Given this list of marker genes Apoa2, Serpinb9, Klre1, Socs5, Rc3h1, Hfe, Inpp5d, Il20rb, Cd84, Jak3, Nectin2, Cd55b, Apoa1, C4bp, Mill1, Sh2d1b2, Arg1, Serping1, Lgals1, Klrb1b, Ceacam1, Zpbp2, Vsig4, BC037156, Cr1l, Grn, Ascl2, Lgals9, Il13ra2, Nod2, Clec4g, Serpinb9c, Zfp35, Hlx, H2-T23, Ccr2, Epx, Hmox1, Tnfsf4, Fgl2, Irf1, Arrb2, Vsir, Parp3, Pglyrp3, Zbtb7b, Serpinb9d, Foxf1, Prg2, Cd59b, Sh2d1b1, Crk, Zp3r, Pglyrp1, Grb2, Pdcd1, Nectin4, Pglyrp2, Vpreb3, Clec12b, Havcr2, Cd69 (CD69 antigen), Tgfb1, Abr, Axl, Muc4, Cd274, Il2, Il4i1, Twist2, Il4ra, Spn, Bst2, Acp5, Cd55, Zc3h12a, Slamf8, Serpinb9h, Il33, Rc3h2, Ahr, Ins2, Loxl3 (NCBI Gene Id 16950), Serpinb9g, Cd300a, Cd46, Tgfb2, Ndfip1, Dusp10, Il7r, Il10, H2-M3, Irak3, Ptpn6, Appl1, Nlrx1, Rps19, Tap2, Fcgr2b, Cd96 (CD96 antigen), Klrd1, Serpinb9e, Foxp3, Masp1, Dusp22, A2m, Ptprc, Lilrb4b, Il4, Angpt1, Spi1, Cd80, Ppp3cb, Cd22, Serpinb9b, Ifnb1, Lilrb4a, Twist1, Rabgef1, Pglyrp4, Pf4, Atg9a, Bcl6, Cd59a, Tnfsf18, Foxj1, Tap1, Igf2, Cr2, Lgals3, Serpinb9f, Ufl1, Fer, Gfer, Tgfb3, Anxa1 (NCBI Gene Id 319730), Tnf, Siglecg, Enpp3, Clec2d (C-type lectin domain family 2, member d), Cuedc2, Ins1, Slamf1, Cx3cr1 (C-X3-C motif chemokine receptor 1), Bcr, Tnfaip3, Tbx21, Susd4 (sushi domain containing 4), Nckap1l, Tmbim6, Smad7, Prkdc, here is a description of the gene set: Mouse Gene Set: GOBP_NEGATIVE_REGULATION_OF_IMMUNE_EFFECTOR_PROCESS studied in species Mus musculus Any process that stops, prevents, or reduces the frequency, rate, or extent of an immune effector process.